The following is a description of a gene set: Any protein complex that is part of a respiratory chain. Mouse Gene Set: GOCC_RESPIRATORY_CHAIN_COMPLEX species: Mus musculus, and this is the list of marker genes: Cox4i2, Atp5me, mt-Nd1, Atp5mj, Cox6b1, AA467197, Dmac2l, Dmac1, Ndufc2, Cox5b, Uqcrb, Uqcrc2, Ndufb3, Ndufa9, Ndufa6, Atp5f1a, Cox7a2, Atp5pd, Cox6c, Ndufa8, mt-Co2, mt-Cytb, Ndufa2, Cox6c2, Cox7b2, mt-Nd2, Sdhd, Cox7a2l, Atp5f1d, Atp6-ps, Cox6a1, Cox7b (NCBI Gene Id 96903), mt-Atp8, Atp5mc1, Atp5mc2, Cox7c (NCBI Gene Id 12867), Ndufs1, Uqcrh-ps1, Sdhc, Sdha, Atg5lrt, Ndufs7, mt-Atp6, Uqcc3, Ndufab1-ps, Ndufv3, Sdhb, mt-Nd3, Uqcr11, Uqcrq (NCBI Gene Id 98240), mt-Nd4l, Cox8b, Uqcrc1, Atp5f1c, Ndufb5, Atp5f1b, Ndufs8, Ndufs6, Ndufa1, Cox5a, Uqcrfs1, Rab5if (NCBI Gene Id 98911), Atp5pb, Stmp1, Ndufab1, Cox6a2 (cytochrome c oxidase subunit 6A2), Atp5mk, Ndufb4b, Ndufs6b, Ndufa12, Uqcrh, Ndufs2, Ndufs4, Wdr93, Uqcr10, Ndufc1, Ndufaf2, Ndufb7, Cox6b2, Ndufb6, Atp5po, Cox8c, Ndufb2 (NADH:ubiquinone oxidoreductase subunit B2), Cyc1, Ndufs5, mt-Nd4, Ndufa13, Ndufa7, Ndufv1, mt-Co1, Atp5mf, Ndufv2, Foxred1 (NCBI Gene Id 235169), mt-Nd6, Ndufa11b, Atp5mg, Ndufb9, Ndufa3, Cox4i1, Ndufs3, Ndufb4c, Ndufb10, Ndufa5, Ndufa11, Atp5mc3, Ndufa4, mt-Co3, Dmac2, Ndufa4l2, Ndufb11, Cox8a, Cox7a1, mt-Nd5, Atp5pf, Ndufa10, Ndufb4 (NCBI Gene Id 68442), Ndufb8, Atp5f1e, Ndufb11b, Ndufb1